Given this list of marker genes DOCK1, PKD1P6, VGLL2, CCR4, MST1, SPON1, FBLL1, ST7 (NCBI Gene Id 93655), CYP2C9, HMGB3P22, ASIC5, DERL3, RGL3, AGMAT, UEVLD, ADAMTSL1, DHPS, ELOF1, CNTNAP1, EMCN, CELF6, ZNF865, PCAT18, ESPL1, DPH2, LRRC4, KLHDC8B, NPM3, DGKA, STK19, RAB5C, BDNF-AS, MLX, SVOP, LINC00605, NFIB, AFAP1L2, FIBIN (NCBI Gene Id 387758), COL5A3, SLC24A5, DGCR5, PINLYP, C22orf15, LAMB2, MAGEA1, LINC00240, THTPA, APOE, CD248, USP21, OOSP2, RELL2, SLC38A5, ZNF93, SLC35G1, PTPRJ, PASK, CYP26B1, OPN5 (opsin 5), TRHDE-AS1, B4GALT3, NRG2, SNHG28, N4BP3, SUSD3 (NCBI Gene Id 203328), NCK2, HUWE1, SHROOM2, CLSTN2, TAAR8, LINC01312, PTCD1, FER1L6-AS1 (FER1L6 antisense RNA 1), ANXA6, ZNF33B, ANKRD13C-DT, FZD10, KCTD4, ATP1A1, KRT38, GTPBP3, CHTF8, ARSK, DNAJC18, CDCA2, HECTD3, E2F4, ELOVL2, FGFBP1, APOBEC4, HABP2, LTK, USP54, TMEM201, DMRTA2, ACVR2B-AS1, SHFL, SLC7A6, PROM1, ZFP42, JDP2, OR51I1, ADGRF3, ATAT1, RDH8, TSPEAR, ALKBH3-AS1, ACSM1, UBQLNL, WAS, UBE2D2, MAP3K15, SLC17A9, POLR2C, IGFL2, SELENOT, SNHG16, CENPV, CXCR6, HTR1F, IFNA7, CHRM3, RRM2, NAV2-AS5, DANCR, PYCR2 (NCBI Gene Id 29920), SYNGR4 (NCBI Gene Id 23546), CAPN6, LIF-AS2 (NCBI Gene Id 91370), ANAPC7, KRTAP11-1, PRPH2, OR10A4, ARHGEF26-AS1, AURKB, PCDH10, C5orf58, CBLIF, RALYL, MIR214, LEMD1, CLDN9, AP3B2, TMEM143, TOM1L2, ZNF747, ZNF236-DT, HVCN1, PDK2 (NCBI Gene Id 5164), TRBV24-1, AQP8, TYSND1, EPHA1, TCF3, PEG10, PRELID3B, LRTM1, DNM1P41, S100A5, ANKRD36BP2, DNAH10, SLC35F4, CPB1, TAAR2, GPRC5D, ZNF250, KIAA1549, AP2B1, WNT10B, MTA3, DENND2C, GRID1, COL4A3, BVES-AS1, ENSG00000204684, CCDC18-AS1, CGNL1, SUN5, KRTAP9-4, PRCD, ZNF862, TRIM49, ADH1C, LINC00692, JTB, KLRB1, HJURP, SNHG29, LINC02874, here is a description of the gene set: Genes down-regulated in monocyte-derived dendritic cells: LPS (3h) versus LPS and LPS like antigen from O. planktothrix (3h). species: Homo sapiens from publication Macagno A, Molteni M, Rinaldi A, Bertoni F, Lanzavecchia A, Rossetti C, Sallusto F (PMID 16717116) Human Gene Set: GSE4748_LPS_VS_LPS_AND_CYANOBACTERIUM_LPSLIKE_STIM_DC_3H_DN A cyanobacterial LPS antagonist prevents endotoxin shock and blocks sustained TLR4 stimulation required for cytokine expression. We report the identification and biologic characterization of an LPS-like molecule extracted from the cyanobacterium Oscillatoria Planktothrix FP1 (CyP).